The following is a description of a gene set: studied in species Homo sapiens Any process that modulates the frequency, rate or extent of the directed movement of lipids into, out of or within a cell, or between cells, by means of some agent such as a transporter or pore. Human Gene Set: GOBP_REGULATION_OF_LIPID_TRANSPORT, and this is the list of marker genes: TRIAP1, CRHR1, ACSL4, EPRS1, ADIPOQ, PRAP1, ATP8A1, ATP8A2, NFKB1, MIR33B, MIR302A, CRH, MYB, PCSK9, MIR206, APOA4, MIR26A1, REPIN1, MIR130B, MIR33A, MIR19B1, CYP4A11, SCP2, YJEFN3, ZDHHC8, MIR27A, ABCA5, ABCA3, AGT, GPS2, MIR613, CRY2, TAC1, BMP6, SEC24A, OSBPL6, GALR1, SHH, MIR17, LRAT (NCBI Gene Id 9227), MIR128-1, CRY1, AVPR1B, PPARG, PLTP, ABCA7, MIR30C1, DAB2, FASLG, ERFE, CAV1, TNFRSF11A, GAL, APOE, P2RX7, FABP3, AGTR1, LDLRAP1, SYK, MIR148A, ECRG4, RXRA, PTGES, OXT, PLA2G10, ABCG1, MIR185, PLA2R1 (NCBI Gene Id 22925), PPARA, NAXE, C1QTNF1, TTC39B, PTCH1, EDN1, TMEM30A, CETP, ABCB4, ABCA1, AKT1, CYP4F2, ACSL5, REN, ABCA2, DBI, TSPO, ITGAV, ITGB3, TMF1, ABCA12, MIR93, LPCAT3, CES1, NUS1, TNFSF11, PLA2G3, APOA2, MIR27B, ABCA13, XRCC4, MIR9-1, APOC2, NR1H3, ACSL1, SURF4, RETN, MIR758, SPP1, POMC, NMB, MIR301B, CYP19A1, ABCG4, AKT2, COMMD1, EEPD1, PRKCD, DISP3, NKX3-1, GDF9, SAR1B, ANXA2, APOA1, IRS2, MIR145, PRKN, ABCA8, PON1, APOC3, TMEM97, PTPN11, LRP1, DENND5B, MIF, GHRL, P2RX4, FURIN, PRELID1 (NCBI Gene Id 27166), ARV1, LAMTOR1, FIS1, APOC1, KCNK9, NTSR1 (neurotensin receptor 1), NFKBIA, LIPG, KDM5B (lysine demethylase 5B), NR1H2, MAPK3, THBS1, PLA2G4A, SIRT1, TREM2, EGF, SREBF2, ANXA2P2, IL1B, MIR144